Given this list of marker genes PRR5, OTUD7B (NCBI Gene Id 56957), SYAP1, NCKAP1L, DEPTOR, GSK3B, MAPKAP1 (MAPK associated protein 1), MTOR (NCBI Gene Id 2476), MLST8, OTUD5, PRR5L, TBK1, PIH1D1, ARMH4, RICTOR, PINK1, RPS6KB1, SIK3, USP9X, AKT1, SESN3, EP300, here is a description of the gene set: species: Homo sapiens A series of intracellular molecular signals mediated by TORC2; TOR (rapamycin-insensitive companion of TOR) in complex with at least Rictor (regulatory-associated protein of TOR), or orthologs of, and other signaling components. Human Gene Set: GOBP_TORC2_SIGNALING